The following is a description of a gene set: Human Gene Set: GOCC_POSTSYNAPTIC_CYTOSOL species: Homo sapiens The region of the cytosol consisting of all cytosol that is part of the postsynapse., and this is the list of marker genes: SENP1, GNAQ, HOMER1, UBE2I, DBN1, FABP5, PLCB1, CALM3, BAIAP2, PIN1, PLCB3, SUMO1 (small ubiquitin like modifier 1), KIF5B, SUMO2, PIAS1, SENP7, NEDD4, SENP5, FUS, CALB1, HTT, KIF5C, UBE3A, DAG1, FBXO45, SYT1, PRKCG, PIAS3, KIF5A